The following is a description of a gene set: Serine proteases. species: Homo sapiens Human Gene Set: MODULE_109, and this is the list of marker genes: GZMB, TMPRSS2, KLK1, KLK10, CFB, PRSS2, PLAT, CELA2A, HPN, C1R, F12, C1S, MST1, PLG, KLK6, GZMH, F10, KLK2, CELA3A, TPSAB1, ELANE, CTSG, CTRC, PROZ, GZMK, PRSS23 (serine protease 23), HTRA1, GZMA, PLAU, GZMM, PRSS8, PROC, PRSS12, HP, F2, C2, F11, CFI, CELA2B